The following is a description of a gene set: Genes down-regulated in MEWO cells (melanoma) after 48h of methionine deprivation. from publication Kokkinakis DM, Brickner AG, Kirkwood JM, Liu X, Goldwasser JE, Kastrama A, Sander C, Bocangel D, Chada S (PMID 16908595) Methionine deprivation stress (MDS) eliminates mitotic activity in melanoma cells regardless of stage, grade, or TP53 status, whereas it has a negligible effect on normal skin fibroblasts. In most cases, apoptosis accounts for the elimination of up to 90% of tumor cells from the culture within 72 hours after MDS, leaving a scattered population of multinucleated resistant cells. Loss of mitosis in tumor cells is associated with marked reduction of cyclin-dependent kinase (CDK) 1 transcription and/or loss of its active form (CDK1-P-Thr(161)), which is coincident with up-regulation of CDKN1A, CDKN1B, and CDKN1C (p21, p27, and p57). Expression of the proapoptotic LITAF, IFNGR, EREG, TNFSF/TNFRSF10 and TNFRSF12, FAS, and RNASEL is primarily up-regulated/induced in cells destined to undergo apoptosis. Loss of Aurora kinase B and BIRC5, which are required for histone H3 phosphorylation, is associated with the accumulation of surviving multinucleated cells. Nevertheless, noncycling survivors of MDS are sensitized to temozolomide, carmustin, and cisplatin to a much greater extent than normal skin fibroblasts possibly because of the suppression of MGMT/TOP1/POLB, MGMT/RAD52/RAD54, and cMET/RADD52, respectively. Sensitivity to these and additional genotoxic agents and radiation may also be acquired due to loss of cMET/OGG1, reduced glutathione reductase levels, and a G(2)-phase block that is a crucial step in the damage response associated with enhancement of drug toxicity. Although the genes controlling mitotic arrest and/or apoptosis in response to low extracellular methionine levels are unknown, it is likely that such control is exerted via the induction/up-regulation of tumor suppressors/growth inhibitor genes, such as TGFB, PTEN, GAS1, EGR3, BTG3, MDA7, and the proteoglycans (LUM, BGN, and DCN), as well as the down-regulation/loss of function of prosurvival genes, such as NFkappaB, MYC, and ERBB2. Although MDS targets several common genes in tumors, mutational variability among melanomas may decide which metabolic and signal transduction pathways will be activated or shutdown. Human Gene Set: KOKKINAKIS_METHIONINE_DEPRIVATION_48HR_DN studied in species Homo sapiens, and this is the list of marker genes: OGG1, PRKCA, LEF1 (NCBI Gene Id 51176), MAPK14, NOXA1, CTPS2, TOP1, DDIT3, TYMS, PDGFD, GSTA4, IFNG, RPS6KA5, TK1, BIRC5, DVL3, MGST3, GSTK1, EBP (NCBI Gene Id 139151), ECHDC2, IRAK1, PMVK, CDK5, MPG, ATF2, RAD54B, HDAC1 (histone deacetylase 1), CEBPG, GSTM5, NME2, CDC25B, IGFBP6, TNFSF13, IGFBP4, IGFBP5, RRM1, UPP1, SOS2, NT5C, FGF2 (NCBI Gene Id 2247), DNMT1, SOS1, MAP3K14, IFRD2, CALM1, MTAP, GSTM1, MTFMT (NCBI Gene Id 123263), IRF7, AKAP9, FGFR1, MET, MYC, IFRD1, SMAD5, CANT1 (calcium activated nucleotidase 1), ATM, CTH, CDA, NME1, AURKB